The following is a description of a gene set: studied in species Homo sapiens Autosomal recessive osteopetrosis pathways Human Gene Set: WP_AUTOSOMAL_RECESSIVE_OSTEOPETROSIS_PATHWAYS, and this is the list of marker genes: TRAF6, CLCN7, TCIRG1, TNFSF11, RAB7A, PLEKHM1, SNX10, TNFRSF11A, NFKB1 (NCBI Gene Id 4790), IKBKB, OSTM1